The following is a description of a gene set: studied in species Homo sapiens from publication Chen Y, Wang X (PMID 31504780) Human Gene Set: MIR432_5P Genes predicted to be targets of miRBase v22 microRNA hsa-miR-432-5p in miRDB v6.0 with MirTarget v4 prediction scores > 80 (high confidence targets)., and this is the list of marker genes: ABHD15, THUMPD1, CLEC12B, BPGM, ZCCHC14, SPRED3, FMO4, DAZ3 (deleted in azoospermia 3), MPP7, ARL5B, ADTRP (NCBI Gene Id 84830), PIK3CB, CDYL, MAN1A2, CCR7, WDFY3, PRIM2 (DNA primase subunit 2), CAVIN2, DHRS7, B3GNTL1, CASP14, MEAK7, QSER1, KLRK1, SPTB (NCBI Gene Id 6710), GPAM, CASP2, PURA, MLLT6, TP53TG3C, GIGYF2, BACE1, LRRC1, PALM2AKAP2, CPEB2, EDA2R, UCK2, SH3TC2, FKBP14, TENT5C, AMD1, ONECUT2, XPNPEP2, CYB5D1, TMEM242, TUBB, FN1, IL7, NFAT5, TUBGCP4, CX3CL1, NR1D1, MTX3, ERBB4, ZNF155, KRTAP19-6, PDGFB, ASPH, SLCO6A1 (solute carrier organic anion transporter family member 6A1), DCPS, COL4A5, UTP23, FBXW7, PLK3, TP53TG3, DEFB110, MRPL34, KCNN3, HSDL2, TBC1D22B, ZNF280C (NCBI Gene Id 55609), TP53TG3D, SLF2, FKBP7, TP53AIP1, E2F3, AAR2, TLN1, EMX2, FNTB, TP53TG3B, SPTY2D1, ZNF621, ADCK1, EPHB2, DAZ2, FAM107B, RGS7BP, ABHD6, GABRA5, LASP1, POLI, ADAR, CELSR2, PPP1R3E, GRAMD2A, HMG20A, MAP3K13, TOX4, AGO1, PGBD4, CACNG4, PRKCB, MBNL2, CDKL5